The following is a description of a gene set: Genes having at least one occurrence of the motif NNNTTCYN in the regions spanning 4 kb centered on their transcription starting sites. This matches the STAT5A transcription factor binding site V$STAT5A_04 (v7.4 TRANSFAC). Human Gene Set: STAT5A_04 species: Homo sapiens, and this is the list of marker genes: HNRNPR, FGF8, IRX3, MRPS18B, FNBP1, STAM, RUNX2, TNMD, GPBP1, ELAVL2, SAMD4A, MBNL1, FGF10, SLF2, NEXN, NKX2-2, PHOX2B, FSIP1, NRF1, POU4F1, NCAM1, SOBP, ZNF654, ZEB2, EDA, FAM81A, CYP17A1, CXCL11, GMCL2, SLC50A1, PLS3, SLC22A23, WSB2, PPARGC1A, TRPS1, DPH2, PHF21A, NMNAT3, NR4A1, GADD45G, VIT, SUMO4, TRPC4AP, EHBP1, SPRY4, MSX2, BDNF, SLC26A3, NOL4, NEUROG2, AP1G2, ITPR1, SETD2, HOXA10, SSBP2, BCL6B, IKZF4, IKZF2 (NCBI Gene Id 51173), PTCHD4, GRIA1, MECOM, P2RY12, HEMGN, CSMD3, MRPS18C, AAK1, NDFIP1, ANKS1B, SKIDA1, BRD4, MTTP, ECHDC2, RYBP, DHRS11, PBK, SOSTDC1, SYTL2, NDUFA4L2, RORB, HOXC13, MAML3 (mastermind like transcriptional coactivator 3), ANKRD28, NTNG2, GPR34, FRMD5, TMEM70, ANKHD1-EIF4EBP3, SMAP2, ARC, ORC4, GRIN2B, OR2K2, OSBPL6, LDB2, BLNK, LINC01931, ERG28, FSTL1, ANKRD1, ARPC2, PPP1R10, PMCH, SLCO1C1, SCG2, ZFPM2, ARIH1, FRA10AC1, FAM24B, BCL9, AGBL4, ZNF385B, ACTN1, CALR, MAP2K7, GRID2, PIK3C2G (NCBI Gene Id 5288), EHD4, PHTF1, PITX2, GMDS, SRSF6, TRIM62, LETM2, MAPK9, MTF2, USO1 (USO1 vesicle transport factor), PTPRD, ETS1, MACO1, ATOH1, TASP1, PAG1, DRD3, TNFRSF19, PRDM1, APBB2, TRPM3, APPL2, BZW1, PPP2R2A, DMD (NCBI Gene Id 548327), FRY, GTPBP2, RNF17, ARL4C, ANKHD1, ABCB1, TFEC, AP4E1, PBX1, BTLA, KANSL2, SREK1, CLDN2, MITF, NFYB, HOXB3, CITED2, HTR3B, CCDC71L, SCYL2, RALGDS, GRB7, TSHZ2, KRT73, IGF1, OR51E2, YIPF3, UPK1B, DPF2, RNF43, DIXDC1, ENSG00000228919, TSHZ3, CIMAP3, GCSAM, FYTTD1, AFAP1, FLI1, PTCH1, FGF14, ALDH1A2, CD40LG, JMJD1C, NRAS, HOXC6, FEZ2, CMYA5, RBM39, CXXC4, DRAM2, CARMIL1, FGF12, MYH3, DUSP9, HOXB6, RBFOX1, CSTPP1, FOXP3, FSIP2, MLXIP, SMOX, FBXL19-AS1, ARRDC3, TLR8, AIF1L, ARK2N, KCTD4, ARFGEF1, NR5A2 (nuclear receptor subfamily 5 group A member 2), CABCOCO1, EXT1, CAPN6, NONO